The following is a description of a gene set: studied in species Mus musculus A specialized area of membrane facing the presynaptic membrane on the tip of the nerve ending and separated from it by a minute cleft (the synaptic cleft). Neurotransmitters cross the synaptic cleft and transmit the signal to the postsynaptic membrane. Mouse Gene Set: GOCC_POSTSYNAPTIC_MEMBRANE, and this is the list of marker genes: Ppp1r9b, Ntrk3, Akap1, Lrfn4, Lrp1, Mkln1, Chrnb3, Cadps2, Grik5, Robo2, Slitrk3, Notch1, Dnm3, Htr3b, Kcnd2, Slc16a7, Slitrk5, Zc4h2, Adra2c, Nptx2, Gphn, Ctnnb1, Usp48, Adgrl3, Drd1, Nsg2, Flrt3, Syndig1, Acp4, Dcc, Gabrg3, Nrcam, Kcnj4, P2rx6, Abhd17a, Rgs7, Htr5a, Pten, Efnb3, Gria4, Abhd17b, Itgb1, Cacng5, Atp2b2, Gabrb2, Hspa8, Grm5, Kcna3, Cacng2, Actn2, Dbnl, Atad1, Clstn1, Drd3, Lrrc7, Chrna10, P2ry1, Kcnc2, Cyth2, Cacng4, Kcnc3, Ptch1, Clstn2, Chrnb4, Clmp, Dgkb, Kcnb1, Tiam1 (T cell lymphoma invasion and metastasis 1), Csmd2, Itga3, Slc1a6, Fxyd6, Slc30a1, Slc6a4, Efnb2, Dlg3, Nsg1, Lrrtm3, Cnksr2, Ptprt, Lin7b, Kcnc4, Ncam1 (NCBI Gene Id 17967), Nrgn, Sez6l (NCBI Gene Id 56747), Sema4d, Chrnb2, Kcnma1, Picalm, Itga8, Tmub1, Grip2, Ptprz1, Sspn, Slc6a9, Gpr158, Lrrc4b, Cdh9, Susd4, Nlgn3, Vwc2, Strn, Prr7, Adra1a, Ddn (dendrin), Nectin3, Asic2, Kctd16, Olfm2, Srgap2, Lrfn5, Rgs7bp, Grm3, Syne1, Lrrtm2, Htr7 (NCBI Gene Id 15566), Igsf9b, C1qb, Kcnh1, Neto1 (NCBI Gene Id 246317), Arrb1, Tacr1, Vdac1, Lrfn2, Htr2a, Magi2, Slc8a2, Scrib, Prrt2, Shc4, Chrne, Adam22, Lrp8, Grm2, Pdlim4, Rapsn, Tamalin, Glrb, Pcdh17, Kcna1, Itgb4 (integrin beta 4), Gabrg1, Dlg2, Napepld, Cadm1 (cell adhesion molecule 1), Fgf22, Drd2 (NCBI Gene Id 13489), Grin1, Scn8a, Erbb4, Sema4c, Fbxo2, Dnaja3, Gabbr2, Adam10, Cdh10, Slc16a3, Grm7, Nlgn2, Adgrb3, Grid2ip (NCBI Gene Id 170935), Cbln1, Dlgap1, Kcna4, Gabre, Chrng, Pacsin1, Syap1, Sema4f, Chrna7, Gabrr2 (NCBI Gene Id 14409), Snta1, Il1rapl1, Rgs9, Glra3, Gria2, Grik2, Elfn2, Lpar1, Cntn1, Gabrr3, Dnm2, Clcn2, Pcdh10, Chrna5 (NCBI Gene Id 11439), Sorcs3, Dag1, Cdh2, P2rx1, Grin2d, Gabbr1 (gamma-aminobutyric acid type B receptor subunit 1), Rab5a, Sorcs2, Shisa8, Slc8a1 (NCBI Gene Id 319418), Hspb1, Cacng7, Adcy1, Shank2 (NCBI Gene Id 210274), Neto2, Grik3, Epha4, Cnih3, Gria1, Olfm1, Lzts1 (NCBI Gene Id 665540), Chrm2, Akap9, Tenm2, Gabra4, Lin7a, Gabra3, Gabrb1, Pcdh8, Shisa6, Grm1, Dlg1, Gabrq, Ache, Rnf10, Rtn4, Slc1a7, Erbb3, Tmem240, Utrn, Oprk1, Adgrl2, Chrna4 (NCBI Gene Id 11438), Grm6, Gabra5, Kcnn2, Kcnc1, Akap5, Slc8a3, Cntn2, Canx, Gnb5, Chrna2 (NCBI Gene Id 211701), Kcnj2, Itgb3, Nptn, Chrm4, Atp6ap2, Slitrk1, Grid2, Chrm1, Kcnd3, Kctd12, Lrrtm4, Mpp2, Clcn3, Musk, Chrna9, Epha7, Apbb1, Gabra6, Trappc4, Plppr4, Elfn1, Nlgn1, Slc6a11, Chrm5, Igsf11, Dagla, Cacna1c, Drd4, Cacna1e, Glra1, Slc6a3, Grik1, Cacng3, Grin3a, Gabrb3, Rac1, Oprm1, Glra2, Flrt2, Ptprs, Gsg1l, Lrfn3, Chrnb1, Adra2a, Htr3a, Gabra1, Stx4a, Lhfpl4, Shank1, Crhr1, Neo1, Snap91, Adora1, Igsf9, Fbxo45, Slc9a5, Gabra2 (NCBI Gene Id 78710), Slc6a6, Chrna1, Gabrd, Cacna1a, C1qc, Epn1, Grin2b, Anp32e, Oprd1, Shisa7, Iqsec2, Glra4, Asic1 (NCBI Gene Id 11419), Adgrb1, Fmr1, Nrg1, Ntrk2, Vangl2 (NCBI Gene Id 93840), Dok7, Drd5, Afdn, Stx1a, Marcks, Plxnb1, Chrna3, Itga5, Nlgn4l, Tmem108, Nrp2, Slc12a5, Kcnt1, Gpr179, Grin2c, Kcnk2, Chrm3, Nrp1, Kcnd1, Cacng8, Chrnd, Slc6a1, Crkl, Nbea, Sema4b, Arrb2, Dmd, Grid1, Abhd17c, Cspg5, Shank3, Gper1, Lrfn1, Lrrtm1, C1qa, Ephb2, Igsf21, Gpr156, Ryk, Iqsec3, Grin2a, Dbn1, Faim2, Grin3b, Comt, Lrrc4c, Arc, Lrrc4, Cacna1h, Gria3, Adora2a, Kcna2, Adrb2, Hcn1, F2r, Lin7c, Abhd6, Grik4, Dgki, Cnih2, Dtnbp1, Ank3, Grip1, Chrna6, Gnao1, Magee1, Erbb2, Ank1, Ank2, Slc6a8, Col13a1, Ptprf, Sigmar1, Met, Prrt1, Rph3a, Shisa9, Ctnna2, Hip1, Kctd8, Syt1, Cacna2d1, Slitrk2, Clstn3, Ptpro, Gabrr1, Trpv1, Kcnab2, Gabrg2, Farp1, Dlg4, Celsr3, Pcdhb16